The following is a description of a gene set: studied in species Homo sapiens A hexameric protein complex required for the initiation and regulation of DNA replication. Human Gene Set: GOCC_MCM_COMPLEX, and this is the list of marker genes: TONSL, MMS22L, MCM7, MCM4, MCMBP, MCM6, MCM8, MCM3, MCM5, MCM9, MCM2